Given this list of marker genes Isg15, Surf1, Irf9, Ahr, Tmod3, Dbndd2 (dysbindin domain containing 2), Faap20, H2ac18, Rhpn2, Pfdn2, Aktip, Psmb9, Tmprss2, Prkab1, Casp1, Zfp97, Ncbp2as2, Mdfic, Chchd10, Cd83, Psmb8, Tst, Tyrobp, Cd24a, Emb, Vamp8, Tgtp1, Eya2, H2-Q10, Man1b1, Rab25 (NCBI Gene Id 99846), Marcks, Ctsc, Pkp4, Slc1a1, Anpep, Cavin2, Sugt1, Lgals3, Sdcbp, Irf7 (NCBI Gene Id 54123), Immp1l, Ppm1b, Eif3e, Krt19, Igkv4-79, Hibadh, Rnaset2b, Ifit1, Ovgp1, Lyz2, Nfib, Lxn, Tes, Rpl36a (ribosomal protein L36A), Pax8, Elf3, Thrsp, Mnat1, Upk3b, Fxyd3, Nsa2, Nudt4, Fam3c, Tmx2, Rtcb, A4galt, Cbr1, Pla2g4a, Nfe2l3, Tspan8, Smim11, Pon2, Hes1, Emp1, Gsta4, Itch, S100a13, Gsto1, H2az2, H2-Q4, Dlx6, Cd53, here is a description of the gene set: Genes co-regulated in uterus during a time course response to progesterone: SOM cluster 9. species: Mus musculus Human infertility and recurrent pregnancy loss caused by implantation defects are poorly understood. Hoxa-10-deficient female mice have severe infertility and recurrent pregnancy loss due to defective uterine implantation. Gene expression profiling experiments reveal that Hoxa-10 is an important regulator of two critical events in implantation: stromal cell proliferation and local immunosuppression. At the time of implantation, Hoxa-10 mediates the progesterone-stimulated proliferation of uterine stromal cells. Hoxa-10 mutants express a stromal cell proliferation defect that is accompanied by quantitative or spatial alterations in the expression of two cyclin-dependent kinase inhibitor genes, p57 and p15. Hoxa-10 deficiency also leads to a severe local immunological disturbance, characterized by a polyclonal proliferation of T cells, that occurs in place of the normal progesterone-mediated immunosuppression in the periimplantation uterus. from publication Yao MW, Lim H, Schust DJ, Choe SE, Farago A, Ding Y, Michaud S, Church GM, Maas RL (PMID 12554760) Mouse Gene Set: YAO_TEMPORAL_RESPONSE_TO_PROGESTERONE_CLUSTER_9